The following is a description of a gene set: Involvement of δ-secretase in neurodegenerative diseases studied in species Homo sapiens Human Gene Set: WP_INVOLVEMENT_OF_SECRETASE_IN_NEURODEGENERATIVE_DISEASES, and this is the list of marker genes: MAOB, BACE1, PPP2CB, MAPT, CEBPB, TARDBP, STAT1 (NCBI Gene Id 6772), SRPK2, SNCA, NTRK2, APP, AKT3, LGMN, AKT1, SET, AKT2, BDNF